Given this list of marker genes SRD5A1, PDE1B, GDE1, SULT1A3, AGMAT, TPH2, SULT1A4, ALDH2, RNF180, BTBD9, GRIN2A, TPH1, DDC, ATP7A, HTR1A, AZIN2, here is a description of the gene set: The chemical reactions and pathways involving primary amino compound. species: Homo sapiens Human Gene Set: GOBP_PRIMARY_AMINO_COMPOUND_METABOLIC_PROCESS